The following is a description of a gene set: Any process that modulates the frequency, rate or extent of the directed movement of peptides, compounds of two or more amino acids where the alpha carboxyl group of one is bound to the alpha amino group of another, into, out of or within a cell, or between cells, by means of some agent such as a transporter or pore. Mouse Gene Set: GOBP_REGULATION_OF_PEPTIDE_TRANSPORT species: Mus musculus, and this is the list of marker genes: Kcnq1, Pde3b (phosphodiesterase 3B, cGMP-inhibited), Prkce, Mup11, Arhgef7, Stxbp4, Srebf1, Nos2, Tm7sf3, Irs2, Lif, Camk2n1, Rasl10b, Rapgef4, Gip, Lrp5, Prkn, Cdk16, Htr2c, Slc2a2, Agt, Grp, Efna5, Mtnr1b, Tiam1, Atg7, Pde1c, Cd74, S100a8, Gper1, Sfrp1, Pdx1, Ppp3cb, Doc2b, Hmgcr, Adcyap1, Aacs, Rest, Ppp3ca, F2 (coagulation factor II), Nr0b2, Ptger4, Ppard, Pla2g6, Ccn3, Pde8b, Per2, Gpld1, Itpr1, Rfx3, Ucn3, Mup1, G6pc2, Sstr5, Gpr39, Tcirg1, Fam3d, Lep, Rab8b, Ghrl, Tnfsf11 (tumor necrosis factor (ligand) superfamily, member 11), Psmd9, Ghrhr, Snap25, Jagn1, Arrb1, Gnas, Fkbp1b, Crhbp, Glud1, Ucn, Fbn1, Slc25a22, Aimp1, Stxbp5l, Piwil4, Drd2, Mup5, Capn10, Rptor, Hnf4a, Trpa1, Hfe, Nmu, Il6, Klf7, Hmgn3, Tfr2, Il1b, Adcy5, Ensa (NCBI Gene Id 99644), Uqcc2, F2rl1, Bglap2, Kalrn, Bmal1, Ghrh, Dynll1, Tardbp, Ptpmt1, Gabbr1, Cftr (cystic fibrosis transmembrane conductance regulator, NCBI Gene Id 547216), Pde4c, Cacna1d, Adora1, Ifng, Slc26a6, Tcf7l2, Bad, Gnao1, Glul, Foxa2, Fgb, Hif1a, Pfkl, Slc30a8, Vsnl1, Birc5, Kcnj6, Oga, Nr1d1, Sybu, Slc9b2, Pax8, Tfap2b, Mir130a, Sytl4, Gja1, Mtnr1a, Ndufaf2, Pck2, Ptbp1, Kcnj11, Orai1, Car2, Nkx6-1, Chga, Clock, Rbp4, Tbc1d1, Cnr1, Oxct1, Nnat, Ptpn11, Mir410, Nr1h4, Cacna1e, Sri, Lrp1, Slc8b1, Myh9, Plcb1, Ffar2, Crh, Npy2r, Gpr68, Midn, Trpm4, Zbed6, Eipr1, Kiss1, Ildr1, Nos1, Mup4, Foxo1, Tunar, Nadk, Mup2, Ptprv, Npff, Anxa7, Slc16a1 (NCBI Gene Id 99768), Cpt1a, Chd7, Ano1, Casr, Sirt1, C1qtnf12, Apln, Eny2, Gnai1, Baiap3, Ffar1, Selenot, Rfx6, Myt1 (NCBI Gene Id 18237), Syt9, Inhbb (NCBI Gene Id 16324), Myrip, Alox5, Adcy8, Uts2, Hmga2, Gipr, Cela2a, Pim3, Acvr1c, Abat, Gprc6a, Trpm5, Prkaca (protein kinase, cAMP dependent, catalytic, alpha), Gcg, Hadh, Pparg, Cartpt, Gnaz, Mcu, Gpr27, Tnf, Crhr2, Fgg, Trpm2, F2rl2, Pask, Hnf1a, Fga, Isl1, Nlgn2, Ucp2, C2cd2l, Acsl4 (NCBI Gene Id 50790, acyl-CoA synthetase long-chain family member 4), S100a9, Map4k4, Anxa5, Cd38, Jak2, Gck, Kcnb1, Abcc8, Ffar3, Ccl5, Ecrg4, Fto, Cckbr, Pex5l (peroxisomal biogenesis factor 5-like), Prkcb, Ffar4, Sox4, Pfkm, Syt7, Lepr, Clcf1 (cardiotrophin-like cytokine factor 1), Rac1, Abca12, Prkar1a, Cask, Mir200a, Cacna1c, Adra2a, Sirt4, Mlxipl, Rph3al, Sidt2, Hcfc1, Stx4a, Sirt3, Gna11, Epha5, Mpc2, Trh, Glp1r, Prkd1, Sct (NCBI Gene Id 20287), Trpc1, Lrrc8a, Egfr, Brsk2, Irs1, Ghsr, Chrm3, Mup3, Pfkfb2, Nucb2, Pick1, Ncoa6, Madd, Gnaq, Blk, Itsn1, Abcg1, Kif5b, Osbp, Serp1, Ptger3, Sirt6, Stim1, Cckar